The following is a description of a gene set: Any process that results in a change in state or activity of a cell or an organism (in terms of movement, secretion, enzyme production, gene expression, etc.) as a result of stimulus by an estrogen, C18 steroid hormones that can stimulate the development of female sexual characteristics. species: Mus musculus Mouse Gene Set: GOBP_RESPONSE_TO_ESTROGEN, and this is the list of marker genes: Slco1b2, Cited4 (Cbp/p300-interacting transactivator, with Glu/Asp-rich carboxy-terminal domain, 4), Mmp14, Rara, Nos1, Naip2, Arsa, Gata4, Krt19, Sra1, Mirlet7e, Mir486, Crh, Hoxa10, Hmox1, Mme, Mir146, Pelp1, Ghrl, Arid5a (NCBI Gene Id 214855), Trim25, Mir672 (microRNA 672), Arsb, Mir145a, Bcas3, Dhh, Mir195a, Rbbp5, Mir142, Mir143, Sts, Tgfbr1, Ghrhr, Ep300, Tbl1x, Mir125a, Gli3, Ash2l, Wbp2, Tgfb2, Ar, Prkaa1, Ctnna1 (NCBI Gene Id 66546), Mapk1, Mir207, Agtr1a, Cd24a, Naip6, Trim24, Abcc2, Abcb11, Cited2, Ocstamp, Mir206, Epo, Cyp27b1, Hoxa11, Mstn, Mir297-1, Gstm5, F7, Mir574, Agtr1b, Gata3, Gba1, Crhbp, Mir451a, Smad6, Mir126a, Mir18, Mir708, Tek, Igfbp2, Mir338, Ctnnb1, Hsp90aa1, Tnfrsf11b, Aqp1, Slc34a2, Mir466, Akr1c6, Gata6, Cited1, Slc10a1, Kcnma1, Abcc9, Mmp2, Star, Kmt2d, Mir148a, Cldn18, Mir125b-1, Esr1, Mir223, Mir3065, Mdm2, Mir493, Sfrp1, Wnt7a, Akr1c20, Tgfb3, Rcan1, Cav1, Sfr1, Zfp366, Naip1